The following is a description of a gene set: A protein ubiquitination process in which a polymer of ubiquitin, formed by linkages between lysine residues at position 6 of the ubiquitin monomers, is added to a protein. K6-linked ubiquitination is involved in DNA repair. Mouse Gene Set: GOBP_PROTEIN_K6_LINKED_UBIQUITINATION species: Mus musculus, and this is the list of marker genes: Bard1, Ube2s, Rnf4, Brca1, Rnf6, Trim21, Ube2d2b, Rnf8, Rnf25, Ube2t, Ube2j2, Prkn, Ube2d3, Rnf14, Wdr24, Ube2srt, Rnf144a